The following is a description of a gene set: Human Gene Set: GOBP_CELLULAR_RESPONSE_TO_LUTEINIZING_HORMONE_STIMULUS Any process that results in a change in state or activity of a cell (in terms of movement, secretion, enzyme production, gene expression, etc.) as a result of a luteinizing hormone stimulus. species: Homo sapiens, and this is the list of marker genes: CCNA2, TOP1, EDNRA, EDN1, LHCGR